Given this list of marker genes Tgfbr1, Smad7, Serpine1 (serine (or cysteine) peptidase inhibitor, clade E, member 1), Lif, Smad1, Eng, Itgb6, Smad6, Foxh1, Runx2, Ski, Fos, Fkbp1a, Tgfbr2, Ifng, Lef1, Bmp4, Stat3, Smad2, Jak1, Thbs1, Smad5, Bambi, Crebbp (NCBI Gene Id 547230), Zeb2, Fst, Skil, Tfe3, Tgif1, Zfp423, Smad4, Egf, Tgfb1, Ltbp1, Ctnnb1, Smad3, Wnt1, Nog, Mapk3, Stat1, Zfyve9, Tgfbr3, Nfkb1, Jun, Tnf, Spp1, Smad9, Mapk9, Ep300, Runx3, Hras, Inhba, here is a description of the gene set: Mouse Gene Set: WP_TGFBETA_SIGNALING_PATHWAY species: Mus musculus TGF-beta signaling pathway